The following is a description of a gene set: Human Gene Set: GSE17721_LPS_VS_CPG_12H_BMDC_DN studied in species Homo sapiens mouse primary BMDCs were stimulated with tlr ligands and gene expression changes were profiled on Affymetrix arrays from publication Amit I, Garber M, Chevrier N, Leite AP, Donner Y, Eisenhaure T, Guttman M, Grenier JK, Li W, Zuk O, Schubert LA, Birditt B, Shay T, Goren A, Zhang X, Smith Z, Deering R, McDonald RC, Cabili M, Bernstein BE, Rinn JL, Meissner A, Root DE, Hacohen N, Regev A (PMID 19729616) Genes down-regulated in comparison of dendritic cells (DC) stimulated with LPS (TLR4 agonist) at 12 h versus DC cells stimulated with CpG DNA (TLR9 agonist) at 12 h., and this is the list of marker genes: EHHADH, CD22, DDIT3, NDEL1, ZDHHC6 (NCBI Gene Id 64429), FBXO21 (NCBI Gene Id 23014), SORBS3, KCNK13, CRISP3, CMTM3, CXCL3, RAI14, WDR12, EVI2A, LTA4H, PWP1, GPRC5B, ANKRA2, EEF1E1 (NCBI Gene Id 9521), ABCB6, FAM181B, PILRA, MARCO, EMC7, CHCHD3, EPHA4, CYB5R1, ANGPTL2, PTPN9, GLIPR1, C3AR1, NFE2L2, SCMH1, PEA15, H2AX, SLC7A7, SLC45A2, CALML4, MPC2, EGR1, TFPI, CHCHD1, TM6SF1, VPS35, POLR1A, TNNT2, SP3, GALK2, EPCAM, ABCC6, HEY2, FKBP1B, HPF1, ASPH, MPHOSPH10, RHBDD3, WFS1, STK32C, MIP, LAMTOR1, NRG4, LCP2, CSRP3, SUSD6, ETS1, TFAP2A, TSPAN14, TOP2B, TNF, ENC1, LIPA, SELENOP, GRIA1, SIDT1, ZFYVE21, TIMM10, GAB1, FOXP1, TLR8, PBDC1, CD9, NRP1, TBRG4, NSMF, TINAGL1, NICN1, IL36G, UAP1L1, CLDN11, ZC3H12C, SLC9B2, LPL, LMO2, SLC35A4, ACSS2, SNX1, MET, DNER, COMT, MYC, EPM2AIP1, NEDD4, B4GALT6 (beta-1,4-galactosyltransferase 6), DAP3, PSEN2, AP1S2, MYL1, CHKB, TMA7, GREM2, PMP22, ACSM3, BAD, IGHM, KAZALD1, SST, TGM2, AIFM1, RAD51, CD72, SLC25A6, LSM14A (NCBI Gene Id 91161), THOC1, PLAUR, YEATS4, CAMK2A, IDH3B, CD68, RENBP, PDXP, TRMT112, TSLP, CCDC65, TBC1D23, LYSMD3, MSR1, P2RY6, ADSL, UBE2C, ARMCX3, RPL19, TOM1, CSF1R, HSPD1, HNF1A, EDN1 (NCBI Gene Id 1906), MFGE8, SLC25A3, PLPBP, PRKD1, HJURP, NAPA, NLGN1, HCCS, NSDHL, ALYREF, CD53, CYP11B2, TRAPPC2B, ADGRE5, OTULINL, LGR5, TRDN, DMBX1, ST6GALNAC2, CLEC6A, POF1B, FDPS, PIK3R1, PPFIBP2, SDHAF2, SDC2, RAB31, NAB2, RAP1A, IDH2, MED8, TRAPPC2, CD48, BPNT1, ASB12 (NCBI Gene Id 142689), PCK2, ETS2, RPL11, MEF2A, PAPOLA, OR51B4, TYMS, IGF2BP2, AKIRIN1, WNT6, DOC2A, ANKH, UBA3, CD93, TAF9, NFAM1, LOXL2, POLDIP2, RPL24